Given this list of marker genes GAB1, FGF10, FGF5, PIK3CA, FGF18, FGF16 (NCBI Gene Id 8823), FGF1, GRB2, FGF7, FGF22 (NCBI Gene Id 27006), FGFR2, FRS2, PTPN11, FGF23, FGF8, FGF4, FGF6, FGF3, PIK3R1 (NCBI Gene Id 5295), FGF20, FGF17, FGF9, FGF2, here is a description of the gene set: part of: Downstream signaling of activated FGFR2 species: Homo sapiens The ability of growth factors to protect from apoptosis is primarily due to the activation of the AKT survival pathway. P-I-3-kinase dependent activation of PDK leads to the activation of AKT which in turn affects the activity or expression of pro-apoptotic factors, which contribute to protection from apoptosis. AKT activation also blocks the activity of GSK-3b which could lead to additional antiapoptotic signals. Reactome Pathway: PI-3K cascade:FGFR2